The following is a description of a gene set: species: Mus musculus Mouse Gene Set: ZHANG_UTERUS_C1_REGENERATIVE_UP Representative genes of 3 sub-clusters of epithelial cells from publication Zhang L, Long W, Xu W, Chen X, Zhao X, Wu B (PMID 35669188), and this is the list of marker genes: Gm6136, Vasp, Gm6444, Ccn1 (NCBI Gene Id 99596), Capg, Cndp2, Sgms2, Ktn1, Qsox1, Slc44a4, Clint1, Sf3b1, Tuba1a (tubulin, alpha 1A), Uap1, Gprc5a, Tmem120a (NCBI Gene Id 215210), Itgb1 (integrin beta 1 (fibronectin receptor beta)), Mdm2, Ube2n, Tnfaip6, Klf4, Ftl1-ps1, Rpl3-ps1, Dstn, Gm9800, Nrtn, Capn5, Lgals3, Lrrc59, Cr1l, Pabpc4, Rps26-ps1, Emp1 (epithelial membrane protein 1), Pmaip1, Cald1, Slc40a1, Gbp4, Actg1, Wdr77, Rab32, Fam107b, Ube2d3, Dalrd3, Pard6b, Lgals1, Itgav, Kcnk1, Tacstd2, Rpsa-ps10, Hk2, Krt19 (keratin 19), Rps15-ps2, Hsp90b1, Hmox1, Muc20, Mrps28, Bltp2, Tgm2, Ftl1, Vim, Ramp3, Aldh1a2, Arpc1b, Sprr1a, Col1a2, Cfb, Wsb1, Perp, Rps6-ps4, Cd2ap, Muc4, Igfbp6, Phlda1, Hmgn2, Cdkn1a, Aldh7a1, Tmbim1, Acsl5, Ccz1, Jchain, Dnajc2, Aars1, Anxa1, Krt8, Anxa6, Tmem9b, Morf4l2, Hnrnpa3, Gm21399, Spon2, Gm7730, Atp6v1a, Rpl18-ps1, Ppp4c, Csrnp1 (NCBI Gene Id 215418, cysteine-serine-rich nuclear protein 1), Ghitm, Gm10086, Ubb-ps, Sat1, Khdrbs1, Msmo1, Blnk, F3, Acot9, Bak1, Snx4, Fosb, Hmgcs1, Trim15, Gm10146, Bcar3, Ptger4, Ncoa7, Pdxdc1, Gm6204, Pgd, Calu, Gm8730, Ap2m1, Socs2, Btg2, Eif4g2, Net1 (NCBI Gene Id 78563), Ssr3, Serpinb1a, Zfand5, Tubb2a, Nfkbia, Gm5905, Cavin3, Oxct1, Serpina1e, Gm10123, Lmna, Hbegf, Epcam, Tram1, Lamc2, Gstp-ps, Uba5, Klf6, Ctnna1, Ppp1r15a, Elf3, Eif4a1, Psmd12, Gm3788, Tmem50b, Ddx47, Sprr2a3, Nutf2, Gm12174, Golm1, Zyx, Lin7c, Cops2, Cd63-ps, Commd1, Col1a1, Trim25, Cnksr1, Krt18, Pgk1, Cttn, Tmem248, Eif3c, Rcn3, Arcn1, Tmprss4, Gm16089, Pigk, Tmed5 (NCBI Gene Id 74336), Rps6, Gm9843, Bace2, Trip10, Tmed4, Sgk1, Endod1, Sptan1, Atf3, Gsta4, Ifrd1, Phb1, Cldn4, Gpd1l, Gm7600, Elovl5, Vcp-rs, Rpl14-ps1, Pim1, Nr4a1, Pkp4, Eef1a1, Gpx1, Krt7, Rpl9-ps6, Rap1b, Tgif1, Tspan1, Capza1, Txnrd1, Gm5436, Sqstm1 (NCBI Gene Id 18412), Ewsr1, Bud23, Errfi1, Gm8797, Anxa3, Ly6a, G6pdx, Dhcr24, Aamp, Tmod3, Adh1, Sfn, Gm15421, Ncstn, Cbr2, Nip7 (NCBI Gene Id 76155), Dpp3, Mxd1, Rpl34-ps1, Car2, Akr1b1, Rpl7-ps9, Gm12350, Gm7658, Padi4, Smox (spermine oxidase), Rps25-ps1, Tfrc, Plaur, Fbln2, Eif4a2, Sulf2, Map2k3, Prap1, Xpnpep1, Tiparp, Plac8, Sh3glb1, Itga6, Rps18-ps3, Pdcd6ip, Gm10039, Nras, Gm15500, Atp2c2, Sptlc2, Mgst3, Gsr, Anxa2, Rnpep, Rps15a-ps6, Snx2, Ccl7, Fbl, Gm13588, Tmbim6, Cyfip1, Gm8203, Sprr2g, Eno1, Gm13456, Rps10-ps2, Lad1, Tnfaip3, Snrpa1 (NCBI Gene Id 68981), Gm16580, Galnt3, Ddit4, Prxl2a, Trib1, Gm4735, Klf5, Gm6807, Hnrnpa1, Col6a4, Dusp1, Ctsc, Maff, Wasl (WASP like actin nucleation promoting factor), Fbl-ps2, Col6a1, Gm10073, Nfkbiz, Rexo2, Kpnb1, Ogdh, Gm3571, Igha, Gm13680, Gm9625, Rpl6l, Ncbp2as2, Wdr1, Gm9892, Gspt1, Ddit4l, Rps3a2 (NCBI Gene Id 100043780), Hspa5, Lum, Gm10250, Adm, Impdh2, Rnd3, Gm3699, Uba52rt, Rpl37rt, Cldn23, Adsl, Capn2, Rpl38-ps2 (ribosomal protein L38, pseudogene 2), Thbs1, Gcat, Tinagl1, Gm15772, Ceacam1, Plk2, Azi2, Padi2, Dnajb4, Gm5835, Rab11fip1, Fuca1, S100a6, Sdf2, Tnpo1, Mfsd4a (NCBI Gene Id 98457), Brcc3, Slu7, Rarres2, Tcim, Gm14017, Gm3150, Cdc42ep5, Cdc42ep3, Gm11560, Clca1, Ccnl1, F2rl1, P2ry14, Mboat2, Txndc5, Hsp25-ps1, Baiap2, Vcl (NCBI Gene Id 268722)